Given this list of marker genes Prkcb, H2-DMa, Ltb, Olfm1 (olfactomedin 1), Gad1, Gbp3, Rag1, Zcchc7, Il4i1, Pygm (muscle glycogen phosphorylase), Sspn, Klf2, Cd1d1 (CD1d1 antigen), Csprs, Macf1, Arhgap45, Cmah, Blk, Cd2 (NCBI Gene Id 12481), Pld4, Txndc16, Iglv3, H2-Ab1, Dgka, Gdi1, Gns, H2-K2, Ifi205, H2-Eb1, Ctsh, Ms4a1, Igkv6-15, H2-DMb1, Ighd, H2-Aa, Ptprc (protein tyrosine phosphatase receptor type C), Klf3, Rbms1, Acp5, Slfn2, Spib, Rgl2, Gga2, Wfdc21, Cd74, Lifr, Mgst1, H2-Ob, Myo7a, H2-Q10, Gucd1, Ero1b, Cd37, Sipa1 (signal-induced proliferation associated gene 1), Unc93b1, Ifi203, Btg1, Arhgef1, Srpk3, Map4k2, Arid3b, Abca1, Evl, Il10ra, here is a description of the gene set: The involvement of the c-Myc transcription factor in neoplastic transformation is well documented. However, which of its numerous target genes are crucial for tumorigenesis remains a frequently contested issue. We have recently established a non-transgenic murine model for B-cell lymphoma based on neoplastic conversion of p53-null bone marrow cells by conditionally active Myc. Using this model, we have identified a number of genes whose expression levels are affected by Myc during B-lymphomagenesis. Here we discuss their possible roles in neoplastic processes and describe an experimental approach allowing in vivo validation of these roles. We demonstrate that lymphoma cells overexpressing one of the Myc targets, the interleukin-10 receptor gene, have a very strong selective advantage over low IL10R expressors. Furthermore, Mcl1, a presumptive IL10R effector, also confers selective advantages when overexpressed in Myc-transformed hematopoietic cells. Thus, both IL10R and Mcl1 might be amenable to therapeutic interventions, and new targets can be identified and validated using the selection approach. from publication Yu D, Cozma D, Park A, Thomas-Tikhonenko A (PMID 16382050) species: Mus musculus Genes down-regulated in B cell lymphoma tumors expressing an activated form of MYC. Mouse Gene Set: YU_MYC_TARGETS_DN